The following is a description of a gene set: species: Homo sapiens Abnormality of the intrinsic pathway An abnormality of the intrinsic pathway (also known as the contact activation pathway) of the coagulation cascade. Human Gene Set: HP_ABNORMALITY_OF_THE_INTRINSIC_PATHWAY, and this is the list of marker genes: MAP2K1, ATP6V0A2 (ATPase H+ transporting V0 subunit a2), SRD5A3, STX5, F9, VWF, DPM2, PMM2, PGM1, SERPINC1, ALG8, MPI (NCBI Gene Id 4351), DPM1, SOS1, ATP6V1E1, PTPN11, F11, SLC37A4, AHCY, MGAT2, ALG9, VKORC1, GGCX, LMAN1, B4GALT1, NGLY1, LZTR1, F12, DPAGT1, ALG2, KNG1, MCFD2, F8, ALG6, BRAF, ALG12, ATP6V1A, THBS2